The following is a description of a gene set: studied in species Homo sapiens A protein complex which is capable of exoribonuclease activity. Human Gene Set: GOCC_EXORIBONUCLEASE_COMPLEX, and this is the list of marker genes: WDR74, ZFP36, KHSRP, DIS3L, EXOSC10, EXOSC5, NVL, DIS3, EXOSC2, MPHOSPH6, EXOSC6, C1D, SUPV3L1, CARHSP1, EXOSC9, LAS1L, PAN2, EXOSC7, MTREX, GTPBP1, ZFC3H1, PNPT1, EXOSC3, EXOSC4, EXOSC8, EXOSC1, PAN3